The following is a description of a gene set: Human Gene Set: GOMF_ADENYLYLTRANSFERASE_ACTIVITY studied in species Homo sapiens Catalysis of the transfer of an adenylyl group to an acceptor., and this is the list of marker genes: FHIT, OASL, FICD, OAS1, MOCS3, NMNAT2, TENT5B, OAS2, GARS1, PAPSS1, FLAD1, MTPAP, PAPSS2, TENT5A, NMNAT1, TENT5C, SELENOO, TENT4B, TENT5D, TUT1, NMNAT3, KARS1, ABL1, COASY, PAPOLA, OAS3, TENT4A, GPHN, TENT2, PAPOLG, PAPOLB